Given this list of marker genes FGF7, OSGIN1, CAB39L, LGR5, NPM3, OFD1, TBC1D24, BAD, ZNF444, HOXB6, GDPD2, ANAPC5, ZNF862, NICOL1, HAP1, TNFRSF4, MARF1, BLCAP, PRNP, B3GNTL1, REEP5, PRSS22, CHST9, PPP1R37, PARVA, SYNE3, TMEM45B, ST6GALNAC6, TRAIP, CHSY3, COL2A1, CHIC1, CASP8AP2, FBXO44, MECP2, CLMP, CCHCR1, PCDH1, KLHDC10, IKZF3, DNMT1, ZCCHC18, MYCL, OR5D18, ERN1, CDC42BPG, COG5, STARD4, S100A4, CCDC141, FOXM1, ASCC2, NFKBIL1, IL21, HYAL3, ACAP3, SPOCK2, PLCB1, AK5, UPP1, PPFIBP2, PDCD1, PAQR3, CLCA1, XPO7, ENTPD1, PLA2G4F, TRAF6, ZFP92, RAB11FIP3, PPP2R1A, YDJC, IL18, LPAR3, RPS6KA2, ICOSLG, XKR6, HLA-DOA, GNG2, LRRC23, HCK, ATP2B4, PHACTR4, SLC26A1 (solute carrier family 26 member 1), PELP1, PMF1, RAB11FIP2, DYNC2H1, PCBP4, PDXK, H2AJ, FCMR, NXN, PRKCA, STXBP1, MYOM2, POLDIP3 (DNA polymerase delta interacting protein 3), ATG4C, ASCL2, ABHD4, NDUFS7, SSH1, RBPMS2, SDHAF1 (NCBI Gene Id 651076), STK19, GOLGA7B, NEK8, SERPINC1, CDH1, FOXC2, WDR76, PCGF2, USP27X, SERPINA9, FGF12, MAB21L2, HEG1, TRAM2, ZBTB7A, RNF183, S100A6, BCR, ZBTB32, CLDN12, SLC16A12, STX11, CHGA, ENPEP, DLX6, AQP11, SNW1, CORO7, IRF5, PRAMEF2, LRGUK, ARF6, IL1R2, TOM1, ADAM15, LRRC74A, STK24, ZNF600, CACNG3, IL17RB, ZBTB16, KCNIP4, TUBB3, CNGB3, SFXN3, DOK4, ACOT1, IL18R1, ASPHD2, IQCE, ERF, CCN6, GSC, SLC44A2, PHGDH, PGD, IL2RA, BAIAP3, OSCP1, CCDC88A, IL1F10, CUBN, TMEM86B, EFNA4, UMODL1, HEBP2 (heme binding protein 2, NCBI Gene Id 23593), NPR1, NEFM, LPXN, S100A10, ERICH6, DMBX1, CMKLR1, KIF9, RFFL, NRN1, GALR2, EVPL, IFT22, KRT2, SPATA19, JDP2, DNAJB5, FLT3, SF3B5, MARCKSL1, NDUFA5, LGALS1, COMMD9, FAM229A, CNTN6, ANKRD35, NDNF, MOCOS, WDFY2, here is a description of the gene set: from publication Szanto A, Balint BL, Nagy ZS, Barta E, Dezso B, Pap A, Szeles L, Poliska S, Oros M, Evans RM, Barak Y, Schwabe J, Nagy L (PMID 21093321) Human Gene Set: GSE16385_UNTREATED_VS_12H_IL4_TREATED_MACROPHAGE_UP Human CD14 positive monocytes were purified from healthy volunteers’ blood and cultured in vitro for 4, 12, 24, 72 hours. While culturing, macrophages were activated alternatively with interleukin-4 (IL-4 100 ng/ml) or classically with interferon-gamma (IFNg 100 ng/ml)+tumor necrosis factor (TNF 50 ng/ml) or left without activation. Simultaneously, macrophages were also treated with vehicle (DMSO:ethanol) or 1mM synthetic PPARg agonist, Rosiglitazone. We used Affymetrix microarrays (U133Plus 2.0) to analyze activation and PPARg-induced gene expression changes. studied in species Homo sapiens Genes up-regulated in macrophages (12h): control versus IL4.